The following is a description of a gene set: Human Gene Set: MORF_PPP1CA Neighborhood of PPP1CA species: Homo sapiens Neighborhood of PPP1CA protein phosphatase 1, catalytic subunit, alpha isoform in the MORF expression compendium, and this is the list of marker genes: PSMA3, RALY, SMARCD2, COX4I1, PSMC3, YWHAZ, COX7A2L, HMGN1, CDIPT (CDP-diacylglycerol--inositol 3-phosphatidyltransferase), EIF3K, PPP1CA, CYC1, MYL11 (NCBI Gene Id 29972), ELOC, ARF3, NEDD8 (NCBI Gene Id 82917), BCAP31, ARHGDIA, RER1, NDUFV1, RAN, COIL, UTP18, UBAP2L, BBLN, PSMD7, POLR2G, DNPEP, HSBP1, BANF1, EIF3C, HDGF, MRPL9, AP1B1, PARK7, COPE, ARPC1B, COX5B, NONO, TMEM147, SF3B2, RPL36AL, CTCF, HNRNPAB, CCT7, COX6C, COX6B1, KARS1, URM1, AP2S1, HSD17B10, HNRNPUL1, DAP, CFDP1, ETFA, NDUFS1, SEM1, MBD4, CLEC18C, SNRPE, UQCRB, GANAB, GATD3, SOD1, CNBP, LSM3, GGCT, SUMO3, SLC25A3, PDAP1, MDH1, HSPD1, RAD23B, PSMD8 (NCBI Gene Id 5714), CNIH1, TECR, CSNK2B, POLE3, DCTN2, ATP5MF, UBE4A, SRSF9, VTI1B, ATP5PD, BUD31, TAF11, BLOC1S1, SNRPG, ATIC, ELOB, CTBP1, RBMX, PRMT1, PDCD6, TUFM, CBX3, STARD7, ENSA, PPP1R7, SSR2, CCT2, SRP9, TBCA, YY1, YWHAB, PPM1G, HSP90AA1, SET, RNF6, STOML2, H2AZ1, COX6A1, NDUFS3, NDUFA1, CANX, TRIM28, SMG7, EIF4H, VCP, PSMD9, PPP2R1A, JTB, HNRNPC, HARS2, HNRNPA3P1, CLTA, CDC123, EEF1D, PRKAR1A, SNRPD2, DDX49 (DEAD-box helicase 49), GABARAPL2, FAM120A, HDAC1, FIBP, PCLAF, KHDRBS1, RAD21, NDUFA2, SKP1, PSMB4, SUMO1, DRG1, PUF60, ANP32B, SRSF3, AP2M1, LYPLA1, SYPL1, TMBIM6, PSMC1, POLR2I, COX5A, ATP5F1C, MBTPS1, ARF5, ATP6AP1, COPS5, PSMC6, MTDH, TMED2, EIF4E2, PPP6C, SUMO2, PSMB1, UBA1, PSMB2, ERP29